Given this list of marker genes Gm57478 (NCBI Gene Id 108168536), Gm20913, Gm21330, Gm28692, Gm21405, Gm29300, Sly, Gm28204, Gm21577, Gm28961 (NCBI Gene Id 102636501), Gm21573, Gm21733 (predicted gene, 21733), Gm21413, Gm21340, Gm21419, Gm28533, Gm20794, Gm28207, Gm21943, Gm21819, Gm21851, Gm21815, Gm20930, Gm28890, Gm28326, Gm29559, Gm21497, Gm28091, Gm21918, Gm21912, Gm21861, Gm21489, Gm29204, Gm28073, Gm21843, Gm21450, Gm21724, Gm21758, Gm20927, Gm28179, Gm20978, Gm28353, Gm28891, Gm28889, Gm28074, Gm21868, Gm29131, Gm21858, Gm20963, Gm28689, Gm21832, Gm20931, Gm21428, Gm29467, Gm28355, Gm21894 (predicted gene, 21894), Gm28284, Gm20871, Gm20987, Gm28350, Gm28165, Gm29466, here is a description of the gene set: Mouse Gene Set: chrYC2 studied in species Mus musculus